The following is a description of a gene set: studied in species Mus musculus part of: Co-stimulation by CD28 electronically inferred by orthology from the curated human pathway This event has been computationally inferred from an event that has been demonstrated in another species.<p>The inference is based on the homology mapping from PANTHER. Briefly, reactions for which all involved PhysicalEntities (in input, output and catalyst) have a mapped orthologue/paralogue (for complexes at least 75% of components must have a mapping) are inferred to the other species. Reactome Pathway: CD28 dependent PI3K/Akt signaling, and this is the list of marker genes: Them4, Rictor, Map3k14, Cd28, Pik3r5, Pik3cb, Pik3r2 (phosphoinositide-3-kinase regulatory subunit 2), Map3k8, Cd80, Fyn, Lck (lymphocyte protein tyrosine kinase), Pdpk1